Given this list of marker genes SLC24A1, NECTIN1, MED16, TSC1, DAP3, ZNF614, RPF1 (ribosome production factor 1 homolog), COMMD2, LDLR, THBS4-AS1, OSBP2, CSHL1, EWSR1, PRKAB2, MRPL48, RUNX1, LINC01600, TIMM10, AP4E1, FKBP3, SPHK2, TDRD7, ADPRS, RNU7-27P, FBXW5, PTMA, CERNA3, DRG2, CACTIN, ACOX3, H4C4, MSC-AS1, ANKRD18CP, RFXANK, BORCS8, CSNK1D, PRPF40A, NCKAP1, CCDC149, DISP3, DNM2, LINC01116 (NCBI Gene Id 375295), RNASEK, SAT1-DT, NFKB2, ALOX12B, SLC35E2B, EML1, MRPS11, NVL, CDK5RAP3, PAWRP1, XPNPEP3, DKK1, FAM110A, NCBP3, PPP1R37, STX16, DHX30 (NCBI Gene Id 22907), IGFL4, LAMP1, BZW1, PRPF18, TMBIM1, CFDP1, HOXA13, OXTR, CCT5, LINC02762, BRWD1, KCNH1, POP7, B4GALT7, CPSF1, KCTD14, EPHB3, HADHB (hydroxyacyl-CoA dehydrogenase trifunctional multienzyme complex subunit beta), UBE2I, BRAT1, REPS1, CLPB, RUVBL1-AS1, ALG5, VARS2, PSIP1, RNU7-29P, TBCK, ACSF3, NRIP3-DT, GLI1, FKRP, PABPC4, MIR7-3, GTF2H4, KDELR1, ANKRD36, SUPT7L, FCHO1, PAXIP1-DT, FAM98B, LIMCH1, ST7, ROBO1, MTERF3, MAP3K7 (NCBI Gene Id 6885), ATG16L1, LINC01775, GCLC, GPBP1L1, GSPT1, TSFM, STX16-NPEPL1, USPL1, STX3, MINCR, ZNF490, CLDN1, TMEM68, NHSL1-AS1, CEMIP, CNNM2, RNF215, PEX3, CHMP3, SIK2, ARID1A, UBTF, COPS7B, SSNA1, TRADD, PTCH1 (NCBI Gene Id 8015), LSM11, SOCS2 (NCBI Gene Id 8835), IPO9, SF3A3, API5, FAM50B, TYRO3, TUBB8, MGRN1, VPS36, HDAC1, FBXO33, CPEB4, ZNF3, XKR6, SYNM, PTK7, PPM1L, CENPS-CORT, DHX33-DT, CNEP1R1, RAB28, MED23, RAD52, ZNF398, ZBTB34, GFI1B, NDUFAF1, COL9A2, CDC40, MYL12-AS1, RWDD1, TMEM106C, RWDD3, RIN1, STAG1-DT, RPL38, MADD, SPECC1-DT, RNASEK-C17orf49, ZRANB2 (zinc finger RANBP2-type containing 2), FAF2, RNU6-9, EXD1, ZNF212, FBXO34, CIMIP5, RPP14, IGFBP3, CCDC144CP, DYNC1LI2, TBL3, ST13, NYAP1, SMARCC2, ODAD1, OTUB1, DDX18, C15orf48, REXO4, PAFAH2, ITGB3BP, EXTL3, HARBI1, LACTB2-AS1, ISY1 (NCBI Gene Id 57461), MIR548AW, PAIP1 (NCBI Gene Id 10605), MANCR, ARTN, C1orf220, CELF1, RPS17, SEMA6B, THSD4, CBY1, DENND6B, RPS4X, SH2D6, MAPK1IP1L, ANKRD46 (NCBI Gene Id 157567), UBB, ZFR, TMEM69, EFCAB7, SYMPK, ZFPL1, POLG, NME1-NME2, RNA5SP158, WIZ, ADORA2A, ELOVL2, RPL7P41, SNORD54, ZMIZ1-AS1, ELDR, MKKS, ATG13, NOSIP, ATPSCKMT, ENSG00000239137, PLEKHG2, CCDC9, ATP8A1-DT, CCT4, CSPP1, ADGRL1-AS1, NDUFS7 (NADH:ubiquinone oxidoreductase core subunit S7), RBIS, DNAJC2, RBBP5, SUDS3, IQCH, UBE2V1P4, DCLRE1B, PPP2CB, SNHG7, DCUN1D3, KDM3B, PTOV1-AS1, ARFGAP3, CNN2, TMPO-AS1, MIA2, THBS1, PPP1R13L, WDR43, MAPKAPK3, TTC39A, PARP3, PIM1, CHD9, NBN, SCRN2 (NCBI Gene Id 90507), CACNA2D4, SPHK1, STX18, DUT, FUS, TSPAN4, MAIP1, COG8, NUP85, UFSP2, ARPC4, FCHSD2, CWC27, PDE2A, PCDHGA11, ANKMY2, H2AJ, ZNF300, MIEN1, CDYL-AS1, ZNF205, ITPRIP, PCBD2, BEND6, FRAT1, NME1, RRP1, NKIRAS2, SRRM5, DDX46, SLC44A1, VPS4A, ZFTA (zinc finger translocation associated), PSME3, PRKCI, VPS37D, RNF214 (ring finger protein 214), SDCBP2, PUS10, PKIA, ERLIN2, CARINH, OGA, SOCS3, C19orf48P, YIPF2, SRI, MOK, RNU1-38P, USP15, ARHGEF1, MYO9B, GATAD1, TBX2-AS1, R3HCC1, SUPV3L1, ELN, YTHDF2, POLR1A, ATG16L2, SVIL, TRIP10, UTP18, EXOSC3, CDK16, H4C16, LPIN3, RBM48, CDCA5, APC2, GORASP2, RAB2B, XPO6, RASD1, LIMD1-AS1, NRIP3, COMMD1, C16orf95-DT, GRIPAP1, MTCH1, PARL, DYNC1LI2-DT, RHOC, DNAAF10, INAVA, ZMIZ1, NPTX1, COL27A1 (NCBI Gene Id 85301), TOR2A, NAPA-AS1, POLR3E, VARS1, STK17A, COPS4, PEX10, SETD5, NDUFAB1, CENPS, LUC7L, PSMD11, EPB41L4A-AS1, NUTM1, SRXN1, TASOR, ZDHHC2, ARHGAP22, BYSL, SPATA20, PPP6R3, ETV2 (ETS variant transcription factor 2, NCBI Gene Id 339321), MAP3K6, SEC22B, VPS18, HDAC2, PSMB7, RNU1-8P, PTOV1, ILF2, MND1, RPL26L1, MIAT, SNHG11, BORCS8-MEF2B, UIMC1, MIA2-AS1, MTBP, FAM83D, CDC16 (NCBI Gene Id 8881), MAPKAPK5, SPOCD1, MAST1, DUT-AS1, CXCL12, SMIM5, AAGAB, AGFG1, SCAP, EXD3, ISY1-RAB43, PCSK7, ANKRD40, SMIM12, BCKDHA, ABCA3, TRAF6, TUBA4A, DHX8, ALG10, ATP6V0CP3, GOLGA3, HMGB1, SS18, CENPE, PNO1, NSFL1C, PDE7B-AS1, SLX9, PDK2, IL18R1, FAM133B (family with sequence similarity 133 member B), FAAP20, MYL12B (NCBI Gene Id 103910), ADPGK, BPTF, DOHH, SYN1, LINC00205, ABHD16A (NCBI Gene Id 7920), ACTB, SNX18, MCM3AP, DPP8, PPARD, MIR6068, PPM1L-DT, CYB561D1, LINC02615, KDM1A, UBE2B, VDAC2, THUMPD3-AS1, POLR2A, CUL2, RPS29 (NCBI Gene Id 6235), CDCA7L, EFNA3, CEP76, SMC3, TACO1, GPR108, SLC4A1AP, SPECC1, ALG10B, HIF1AN, POC1B-GALNT4, COMMD6, MTMR14, U2AF2, GPATCH2, TTLL12, OXR1, RBM45, RAPGEF3, CFAP96, DOP1A, DUSP11, NDUFAF4, TBC1D19, RNASE4 (ribonuclease A family member 4), FRS3, ESR2, LRRC41, PAK4, POLR2J4, FOS, LRRC71, GCLM, ARHGAP1, LTBP1, RNF130, COIL, TMEM170A, SACM1L (SAC1 like phosphatidylinositide phosphatase), BEND3, TMEM222, RPS7, MAML3, RPL26L1-AS1, TTLL7, NOXA1, KCTD18, CDIPTOSP, ENSG00000236543, AKIRIN1 (akirin 1), PIK3R3, FOXCUT, ZCCHC4, SGO2, POR, RPN2, BCL2L1, ENPP3, BAG3, TMBIM6, ASF1B, FRAT2, TJP3, ATP8A1, SEC14L1, ZNF165, IER2, FUCA1, WDR36, PDIA6, ZER1, CDK11A, HNRNPDL, CWC25, RITA1, SH3GL1, CITED2, CIRBP, SEH1L, DHX34, SMIM29, TOX4, COMTD1, ADGRL1, TADA3, LINC02453, ZDHHC6, NDST2, SLC39A8, BECN1, MED20, TOMM20L, PCBP2, TAFA2, BANF1, CDKL3, SLBP, EIF1AD, AARS2 (alanyl-tRNA synthetase 2, mitochondrial), PML, WNK1, LRP4, NOG, TRAM1, TRMT44, UQCC6, BCAS4, EARS2, VPS9D1, GINS4 (GINS complex subunit 4), KMT5B, FNBP1P1, SAR1B, FAM20B, DIAPH1, SMARCD1, REG4, USHBP1, KCNH1-IT1, ASAH1, HAUS8, SYCE3, RHBDD1, HADHA, HYCC2, H4C12, TMPOP1, ENSG00000266313, FLT3LG, PLXDC1, RPS14, DDX47, VRTN, PTK6, METTL15, ANG, CMC2, SUFU, FAM187A, TGFB1I1, MIR3185, TPBG, EEF1D, C1QBP, TMEM41A, HYAL2, ALKBH3, CFAP221 (NCBI Gene Id 200373), METTL5, IPO9-AS1, RPL21, METTL26, OXR1-AS1, MAPT (NCBI Gene Id 8152), YY1AP1, DNLZ, CLDN16, UBC, SNORA13, ENSG00000248161, MED4, TP53, WASF2, SCAI, SLC9A7, MRPL1, PRPSAP1, MROH8, LMAN2, PLEKHJ1 (NCBI Gene Id 55111), TNFAIP3, IBA57, BZW2, TLCD1, DPP9, NOCT, HOXA5, CCDC142, VPS51, MPLKIP, PSMD6, PPP1R3B, AAAS, NUP107, C8G, CD164, PEMT, LINC02574, GTF3C5, ZNF408, ZNF329, EMC1, NSL1, DNAJC14, SEC61B, KPTN, PLK2, DGAT2-DT, NDUFB3, ANKRD18DP, RWDD3-DT, FRA10AC1 (FRA10A associated CGG repeat 1), SMC1A, LYRM1, CPED1, SLC12A9, KCNAB2, MIR638, UTP3, TEX2, ZNF629, EIF3F, CCBE1, ZNF839, PAXIP1, NDUFB7, INTS1, TJP2 (NCBI Gene Id 9414), MRPL13 (mitochondrial ribosomal protein L13), ENSG00000263280, TNFRSF8, RAB3IL1, RPL19, VTI1A, MIR4727, RNF150, QRICH1, NOP10, RCL1, PLEKHH3, GET3, POLR3F, LRRC37B, TATDN3, GOSR1, ENSG00000232995, H4C8, ARPC4-TTLL3, MRPL39 (mitochondrial ribosomal protein L39), SUMO2, TGS1, RPL18, ZNF213-AS1 (ZNF213 antisense RNA 1 (head to head)), DCTN1, TMEM198B, TYW5, GUSBP1, SPATA17, TOMM22, SRRM3 (NCBI Gene Id 222183), WDR38, NUP107-DT, RPL22, GSTP1, PFKFB3-AS1, TAS1R1, COPS9, PHAX, MAPKAPK5-AS1, MARCHF10, TRIM59-IFT80, TPBGL-AS1, ABCA17P, TIMM44, KIFC1, STAG1, EXOC7, ADHFE1, TRIM59, LINC01547, STOML1 (stomatin like 1), VPS13D, TCP11L2, UFD1, GNB2, TMEM242, AP3S2, PDZD9 (PDZ domain containing 9), MIR153-1, PDS5B, YBEY, BRPF1, LINC02980, GFM2, PSMD3, UBE3B, MBTPS2, ABCC5, MNT, C1QL4, KMT2A, C1orf52, BBS1, LINC02332, PRKG1-AS1, VTRNA1-3, ERI2, MYL12A, RIBC1, PINK1, ANKRD13A, CCDC107, EED, EP400, C6orf62, SNHG17, NIP7, HIC1, ZNF554, AP4B1, NAPA, CA13, H2AZ2-DT, CDYL, COPS8-DT, EIF3G, TCERG1, CYREN, AFF1, IRGQ, WDR24, PFKFB3, WASF1, LINC01385, RNY3, LINC02324, VTI1B, STX18-AS1, GTF3C3, GSTA4 (glutathione S-transferase alpha 4), LINC01569, MIR6781, EXOSC5, AIMP1, TFEB, ARK2N, ITGB5, FGF7, FAM3C, ABCD4, MTERF1, POLG-DT, TSEN54, PRMT1, LINC01829, ITPR1, NUF2, EFTUD2, HTD2, ZNF341, CASKIN2, TOP3B, NSA2 (NCBI Gene Id 10412), GSE1, MYNN (myoneurin), TMEM201, FMNL3, TAP2, MCRIP2, FAM227A, PFDN4, PXN-AS1, ANKS6, ENSG00000225649, MFSD3, PAFAH1B3, FBXO34-AS1, ST3GAL2, RHBDD3, DPCD, CHCT1, DENR, EHD2, WDR70, NOB1, ANAPC7, ADNP, RHOT2, CFAP54, SNAPC4, SLC39A3, CENPN, GRAMD1C, KCNIP2, ASAH1-AS1, CCDC103, SMARCD2, ISCA2P1, ZNF76, PPM1F, RPLP0, ALDH4A1, TRPC4AP, MIR5188, RPS20, VPS72, INTS14 (NCBI Gene Id 81556), DUSP13B, MKRN2, FXN, PPM1J, POLR1F (RNA polymerase I subunit F), UBE4B, MGAT5B, POLR1G, BOLA3, PDE6D, ACBD4, POC1B (POC1 centriolar protein B), TRDMT1, RSAD1 (radical S-adenosyl methionine domain containing 1), PRRG2, KRAS, PSMC3, NECTIN1-DT, NKAPD1, MIR9-2HG (MIR9-2 host gene), WRAP53, BCO2, ARL8B (ADP ribosylation factor like GTPase 8B), ANKRD36B, RPSAP31, RN7SK, MBTD1, MRPL38, LINC02768, SYVN1, RPA2, SEMA3B (NCBI Gene Id 7869), SUGCT, LINC01749, NCOA7, SNRPD1, COPS5, DZANK1, TAF1C, UQCRC2 (ubiquinol-cytochrome c reductase core protein 2), ADAT2, ASB6, WDR11, SF3A2, DST, MIR7-3HG, ERCC1, TIMM29, OTUD3, SMG8, NOTUM, RGS9, ANAPC2, SATB2 (NCBI Gene Id 80104), SNHG29, FEM1A, ZNF276, SLC9A1, CFAP276, H4C3, UPF2, GH1, PSORS1C1, AP5S1, DNAAF3, CSNK2A1, ZNF628, SAT1, VPS52, PTCD3, PDAP1, RAF1, PDE4A, RNF216, PEX13, KCNT1, CDC45, CCDC144BP, CAB39, ARL6IP6, RAPGEF1, RAB11A, FRG1HP, DDX54, UBFD1, RNU2-37P (NCBI Gene Id 106480213), H3C6, ABLIM3, DUS1L, RGS5, RPS18, HSPA6, FANCM, SAMD4B, RBM28, TBC1D28, TIGD5, SASH1, KCTD10, EIF2D, NUS1, RRP9, COPS8, NOL9, LINC01140, KCNIP2-AS1, ARL4A, RBM17, MRTO4, PHRF1, POLR2L, C20orf203, CHP1 (NCBI Gene Id 11261), PRDM8 (NCBI Gene Id 56978), TOMM22-DT, NR2F1-AS1, ALG2, SPINT2, BCL6, KLHL20, UBE3D, LRRC59, BNIP1, DEF8, PTDSS1, ZNF219, RBBP6, BOLA3-DT, RAG1, WDR11-DT, UQCRH, CBL, H4C11 (H4 clustered histone 11), CDO1, MCM4, DGAT2, NR6A1, RMRP, PIH1D2, DHX33, SELENOW, BOD1, SNAP25-AS1, LRPPRC (leucine rich pentatricopeptide repeat containing), DGKZ, CACNA1H, ABT1, SREK1IP1, CFAP77, SNHG20, PRKDC, DLST, HDAC2-AS2, CDIPT, ZBTB4, MIPEP, TOMM20L-DT, ELOVL2-AS1, IBA57-DT, MAT2A (methionine adenosyltransferase 2A), BUD31, UCHL3, MRPL46, USP30, PSMC2, PDE2A-AS1, HROB, PSMG2, NUP54 (NCBI Gene Id 53371), TMEM242-DT, CSTPP1, ZNF576, SNORD49B, INSL6, ELAPOR1, PLEKHG4, REX1BD, ENSG00000273145, SNX32, ZRANB2-DT, ATP6V0A1, SUZ12P1, PEX1, here is a description of the gene set: Genes containing one or more binding sites for (SUMO1) in their promoter regions (TSS -1000,+100 bp) as identified by GTRD version 20.06 ChIP-seq harmonization. from publication Yevshin I, Sharipov R, Kolmykov S, Kondrakhin Y, Kolpakov F (PMID 30445619) Human Gene Set: SUMO1_TARGET_GENES species: Homo sapiens